Given this list of marker genes PSMD2, RHOG, ARHGDIA, PTTG1, FSCN1, EIF4A1, ITGA5, ARHGAP1, RRAS (RAS related), here is a description of the gene set: Human pituitary tumor-transforming 1 (PTTG1)/securin is a putative oncoprotein that is overexpressed in various tumor types. However, the involvement of PTTG1 in gastrointestinal cancer development and progression remains unclear. In this study, we investigated the clinical significance and biological effects of PTTG1 in esophageal squamous cell carcinoma (ESCC). Immunohistochemical studies performed on 113 primary ESCC specimens revealed a high prevalence of PTTG1 overexpression (60.2%), which was significantly associated with lymph node metastasis (regional, P = 0.042; distant, P = 0.005), advanced tumor stage (P = 0.028), and poorer overall survival (P = 0.017, log-rank test; P = 0.044, Cox proportional hazard model). Eleven ESCC cell lines expressed PTTG1 protein at levels 2.4 to 6.6 times higher than those in normal esophageal epithelial cells (HEEpiC). PTTG1 protein expression was confined to the nucleus in HEEpiC cells but present in both the cytoplasm and nucleus in ESCC cells. Two small interfering RNAs (siRNA) inhibited PTTG1 mRNA and protein expression in three ESCC cell lines by 77% to 97%. In addition, PTTG1 down-regulation by these siRNAs significantly reduced cell motility in all three ESCC cell lines (P < 0.01) in vitro, as well as popliteal lymph node metastases of ESCC cells in nude mice (P = 0.020). Global gene expression profiling suggested that several members of the Ras and Rho gene families, including RRAS, RHOG, ARHGAP1, and ARHGADIA, represented potential downstream genes in the PTTG1 pathway. Taken together, these findings suggest that PTTG1 overexpression promotes cell motility and lymph node metastasis in ESCC patients, leading to poorer survival. Thus, PTTG1 constitutes a potential biomarker and therapeutic target in ESCCs with lymph node metastases. Human Gene Set: ITO_PTTG1_TARGETS_DN from publication Ito T, Shimada Y, Kan T, David S, Cheng Y, Mori Y, Agarwal R, Paun B, Jin Z, Olaru A, Hamilton JP, Yang J, Abraham JM, Meltzer SJ, Sato F (PMID 18451147) Genes down-regulated in HSA/c and KYSE140 cells (esophageal squamous cell carcinoma, ESCC) after knockdown of PTTG1 by RNAi. studied in species Homo sapiens